Given this list of marker genes PIK3CA, AKT2, AKT1, RPS6KB1, AKT3, RPS6KB2, MTOR, here is a description of the gene set: studied in species Homo sapiens Human Gene Set: KEGG_MEDICUS_VARIANT_MUTATION_ACTIVATED_PI3K_TO_PI3K_SIGNALING_PATHWAY Mutation-activated PI3K to PI3K signaling pathway. Pathway ID: N00049. Pathway type: Variant. Pathway class: nt06263 Hepatocellular carcinoma. Pathway Definition from KEGG: PI3K* -> PIP3 -> AKT -> MTOR -> S6K